Given this list of marker genes PLA2G2A, PLA2G3, PLA2G4A, PLA2G5, PLA2G4B, PLA2G12A, LPGAT1, PLA2G2E, PLA2G1B, PLA2G2D, PLA2G4F, LPCAT4, PLA2G4D, PLA2R1, LPCAT1, PLA2G10, CRLS1, PLA2G2F, here is a description of the gene set: Acyl chain remodelling of PG Human Gene Set: REACTOME_ACYL_CHAIN_REMODELLING_OF_PG studied in species Homo sapiens